The following is a description of a gene set: species: Homo sapiens from publication Chen Y, Wang X (PMID 31504780) Human Gene Set: MIR5591_3P Genes predicted to be targets of miRBase v22 microRNA hsa-miR-5591-3p in miRDB v6.0 with MirTarget v4 prediction scores > 80 (high confidence targets)., and this is the list of marker genes: A2ML1, COL4A1, LEPR, CLEC3A, MTMR10, PMAIP1, SYNJ1, SPCS2, IQCK, PATE2, SIM1, USP27X, UPF1, CPEB3, EPAS1, ME2, XPR1, TGFBRAP1, RRP1B, ZMAT3, POLR2M, SLC66A3, ZBTB34, ACTR2, RFX4, UPB1, JPH3, PCDHB3, VEZF1, SBNO1, TBC1D22B, JPH1, DNAJC3, CDR2L, CD8A, ARHGAP36, GCOM1, RBBP6, ASTN2, MYCN, HDAC6, PJA2, VPS13B, CLCA2, HIPK1, HIF1A